Given this list of marker genes CDK20, GLI2, SHH, CLUAP1, SMO, GLI1, here is a description of the gene set: The process whose specific outcome is the progression of the ventral midline over time, from its formation to the mature structure. In protostomes (such as insects, snails and worms) as well as deuterostomes (vertebrates), the midline is an embryonic region that functions in patterning of the adjacent nervous tissue. The ventral midline in insects is a cell population extending along the ventral surface of the embryo and is the region from which cells detach to form the ventrally located nerve cords. In vertebrates, the midline is originally located dorsally. During development, it folds inwards and becomes the ventral part of the dorsally located neural tube and is then called the ventral midline, or floor plate. Human Gene Set: GOBP_VENTRAL_MIDLINE_DEVELOPMENT studied in species Homo sapiens